Given this list of marker genes PSME3, MGMT, PPFIBP1, TOR3A, KIF13A, TMEM165 (transmembrane protein 165), RAB8B, GNAQ, IGBP1, POLD4, SH3BGRL2, NF1, TSR2, TNFSF13B, GRHL1, MRPL45, CHCHD3, CLCC1, IL1R2, RBPJ, SPCS3, MAB21L1, RIDA, SYNPO, ABITRAM, CLDN25, MINDY4, DNASE2B, EPCAM, IFT20, UMPS, SPRED1, PDCD1LG2, ASAP1, CIMAP1A, CEBPA, IDH3G, ZC4H2, GPLD1, NRN1, THOC3, IFT52, FGD6, SSR4 (NCBI Gene Id 6748), NUP93, BCAT1, MATN2, ATAD1, CANX, PENK, PHACTR2, RAB28, ME1, SEPTIN7, SDCBP, TANK, CD27, GUCY1A1, PRPF31, PAFAH1B2, PRKCA, HIVEP3 (HIVEP zinc finger 3), FSHR, HGF, PSMD14, SAMD4A (NCBI Gene Id 26078), LAP3, CHTF18, SPACA5, RGS9, ASCC2, YBX3, RAD51B, ASNSD1, ANKLE2, TCEAL9, TRIP13, ABCD3, GPM6B, MARCKSL1, RYK, GFM2, RABL2A, GABARAPL1, REPS1, SCAMP1 (NCBI Gene Id 9522), HMGN2, ICA1, ITGB8, COPS7B, METTL1, PLAGL2, LARP1B (NCBI Gene Id 84199), TSHZ2, ARHGAP24, PLEK, IFITM2, SLC35A1, BPHL, DGUOK, BATF, BCL2L1, TIMM17B, EI24, NPAS4, CSF1, IFNG (NCBI Gene Id 3458), S100A14, OCIAD1, CYBB, PSME1, SLC35F5, LCLAT1, DPYD, CDC14A (NCBI Gene Id 8556), DAPP1, CD52, SLC22A15 (solute carrier family 22 member 15), TXN, GPR174, TMEM9, SLC43A3, RYR2, NSFL1C, CD81, SFMBT1, YBX1, CST7, ATPAF2, CRYZ, ABCG2, FNDC7, SCIN, DDC, MTREX, CD38, RRAGD, FLNB, YIPF5, AHI1, FAM162A, ARRDC4, TBC1D7, DSTYK, SF3A1, INPP5B, ADGRD1, TIGIT, ACOT12, MCTP1, VDR, JAZF1, METAP1, SLC12A2, NIT1, MTFR1L, TMEM63C, EEA1, IMMP2L, SUMO2, CDC26, JAGN1, PMPCA, FCRL5, ETFB, IFT88 (intraflagellar transport 88), CRELD2, TMEM38B, here is a description of the gene set: Human Gene Set: GSE37605_C57BL6_VS_NOD_FOXP3_FUSION_GFP_TCONV_UP The aim of this study was to quantify the impact of chimeric Foxp3-GFP protein on the Treg cell transcriptional program. studied in species Homo sapiens Genes up-regulated in Foxp3-Fusion-GFP T conv (FOXP3-): B6 versus NOD background. from publication Darce J, Rudra D, Li L, Nishio J, Cipolletta D, Rudensky AY, Mathis D, Benoist C (PMID 22579475)